The following is a description of a gene set: Human Gene Set: MIR3681_5P studied in species Homo sapiens from publication Chen Y, Wang X (PMID 31504780) Genes predicted to be targets of miRBase v22 microRNA hsa-miR-3681-5p in miRDB v6.0 with MirTarget v4 prediction scores > 80 (high confidence targets)., and this is the list of marker genes: METTL4, CDH12, NKD1, MLLT10, CTXN2, CDH6, SHISA7, CSDE1, LRRN4CL, CCDC68 (NCBI Gene Id 80323), KDM5A, CCR1, CHST9, ACVR1C, YPEL4, HPSE, TMPRSS11D, EFEMP1, FMO5, NOMO3, CRACDL, FUT10, TTC29, TIMM23B, NRG4, NOMO2, LAMA3, KCNJ13, ZNF124, NDP, NOMO1, KIN, NEMP2, ECT2, AXIN2, PLPP3